Given this list of marker genes Ifi205, Nfkbiz, Cygb, Mt1, Ndrg1, Ifi203, Adamts5, Txnrd1, Myc, Nfkbia (nuclear factor of kappa light polypeptide gene enhancer in B cells inhibitor, alpha), Clec3b, Anxa3 (annexin A3), Hsd11b1, Mgst1, Ddx5, Gstt1, Sbds, Hsp90ab1, Socs3, Chd4, Capg, Ifit1, Hspa8, Procr, Cyba, Trf (transferrin), S100a6, Aldh2, Plac9, Fos, Cxcl1, C4b, AW112010, Myoc, Crispld2, Lum, Lrrn4cl, Gpnmb, Dcn, Hspb1, Nfe2l2, Smoc2, Id3 (inhibitor of DNA binding 3), Cdkn1a, Gja1, Thbs1, Tmem176b, Psap, Apod, Efemp1, Il6, Zfp36l1, Tac1, Inmt, Iigp1, Junb, Fosl2, Clu, Tspo, Hsp90aa1, Slc10a6, Zfp36, Ier3, Aspn, H2-D1, Casp4, Sod2, C1s1, Cst3, Cebpd, Kdm6b, Camk2n1, Malat1, Ly6c1, Ifi211, G530011O06Rikx, Ms4a4d, Osmr, Ces1d, Abca8a, Gpm6b, Ptgs2, Ccl19, Cd74, Nop58, Ifi204, Fth1, H2-K1, Gsn, Nfil3, Prr13 (NCBI Gene Id 72100), Gstm1 (NCBI Gene Id 14862), Fbln2, Sbno2, Ftl1, Cxcl2, Pla1a (phospholipase A1 member A), Has1, Ifitm3, Arpc3, Hspa5, Cfh, Mt2, Gadd45b, Cebpb, Hspa1a, Nmb, Gem, Gpx3, Ccl11, Sgce, Pdpn, Tuba4a, Thbd, Psmb8, Tnfaip2, Hnrnpa2b1, Gfpt2, Rtp4, Aldoa, Bcl3, Cpq, Egr1, Ecm1, Serpine2, Cyb5a, Ifi207, Uap1, Dpep1, H2-Q4, Gadd45a, Nr4a1, Ccnl1, Serping1, S100a4, Enpp2, Tpm3, Lgals3, Cd302, C3, Cilp, Hk2, Cfb, Rrad, Gstp1, Irf1, Tiparp, B2m, Serpinb6a, Srrm2, S100a13, Cd9, Anxa1, Ogn, Anxa5, Irgm1, Isg15, Ly6a, Tnfaip6, Eif4a1, Rps27, Sparcl1, Gadd45g, Plscr1, Itm2b, Klf2, Ptx3, Ubc, Apoe, Sqstm1, Pltp, Plpp3, Plat, Cxcl12, Cd47, Tnfsf9, C1ra, Plau, Icam1, Il33, Rarres2, here is a description of the gene set: studied in species Mus musculus from publication Tabula Muris Consortium (PMID 32669714) Mouse Gene Set: TABULA_MURIS_SENIS_LIMB_MUSCLE_MESENCHYMAL_STEM_CELL_AGEING